The following is a description of a gene set: The process whose specific outcome is the progression of the cardiac myofibril over time, from its formation to the mature structure. A cardiac myofibril is a myofibril specific to cardiac muscle cells. studied in species Mus musculus Mouse Gene Set: GOBP_CARDIAC_MYOFIBRIL_ASSEMBLY, and this is the list of marker genes: Csrp3, Nebl, Pdgfrb, Mef2a, Nrap, Fhod3, Actc1, Neb, Srf (NCBI Gene Id 224821), Myh10, Ttn, Mylk3, Nkx2-5, Adprhl1, Cavin4, Smad4, Pdgfra, Prox1, Tcap, Myl2